Given this list of marker genes Fzd9, Cacnb4, Cacna2d2, Six4, Crk, P2rx2, Cntnap1, Col4a1, Pdzd11 (NCBI Gene Id 72621), Tnc (NCBI Gene Id 21923), Ptn, Crkl, Lin7c, Fnta, Large1, Pak1, Sorbs1, Dok7, Rer1, Sptbn4, Ppfibp2, Mycbp2, Gsk3b, Sorbs2, Kalrn, Dctn1 (dynactin 1), Erbb2, Dvl1, Nedd4, Lin7a, Afg3l2, Cntnap2, Kcnj8, Ppfibp1, Etv5, App, Lamb2, Spg11, Cacng2, Ky, Slc18a3, Unc13b, Farp1, Ank3, Chrna1, Rac1, Lrrk2, Rapsn, Musk, Lin7b, Six1, F2r, Zc4h2, Cacna1s, Agrn, Pdzrn3, Pmp22, Lrp5, Gphn (gephyrin), Snta1, Dnaja3, Fgfr2, Chat, Col4a5, Unc13a (NCBI Gene Id 73695, unc-13 homolog A), Als2, Mesd (NCBI Gene Id 67943), Nedd4l, Colq, Lrp4, here is a description of the gene set: Mouse Gene Set: GOBP_NEUROMUSCULAR_JUNCTION_DEVELOPMENT A process that is carried out at the cellular level which results in the assembly, arrangement of constituent parts, or disassembly of a neuromuscular junction. studied in species Mus musculus